The following is a description of a gene set: species: Homo sapiens from publication Schaefer CF, Anthony K, Krupa S, Buchoff J, Day M, Hannay T, Buetow KH (PMID 18832364) Hypoxic and oxygen homeostasis regulation of HIF-1-alpha Human Gene Set: PID_HIF1A_PATHWAY, and this is the list of marker genes: EGLN2, OS9, HSP90AA1, HIF3A, CDKN2A, NAA10, VHL (NCBI Gene Id 8056), HIF1A, ARNT, CUL2, RBX1, HIF1AN (NCBI Gene Id 84175), ELOB, TP53, RACK1, ELOC, EGLN1, EGLN3, COPS5